Given this list of marker genes Rdh10, Lss, Rdh16f2, Rdh9, Aldh1a3, Akr1c18, Rdh16, Fdps (NCBI Gene Id 99573), Dhrs9, Rpe65, Rdh1, Hmgcs2, Ggps1, Aldh1a1, Aldh8a1, Cyp1a1, Aldh1a2, Hmgcs1, Rbp1, Rdh19, Prmt3, here is a description of the gene set: The chemical reactions and pathways resulting in the formation of terpenoids, any member of a class of compounds characterized by an isoprenoid chemical structure. Mouse Gene Set: GOBP_TERPENOID_BIOSYNTHETIC_PROCESS species: Mus musculus